Given this list of marker genes Atp1b1 (NCBI Gene Id 11931), Ccdc178, Eef1a1, Clec4b2, Mapk14, Tardbp, Ppp2cb, Chfr, Pdcd6ip, Elmo1, Tlx1, Rtn4rl1, Rit2 (NCBI Gene Id 56511), Sycp3 (NCBI Gene Id 20962), Ugcg, Ppp4r2 (protein phosphatase 4, regulatory subunit 2), Arid4a, Stmn1 (NCBI Gene Id 16765), Larp4b, Gnb1, Stag2, Uso1, Bicd2, Zic2, Dtwd2, Ubxn7, Tmx3, Fam135a, Dnajc21, Hells, Ralgapa2, Xirp2, Tmem265 (transmembrane protein 265), Bahd1, Rab38, Zbtb41, Arl4a, Cd300ld, Ptchd4, Cdan1, Unc5d, Rfxap, Fem1a, Ino80d, Cachd1, Lrrc39, Col11a2, Selenot, Zbed6, Cnn3, Zfp318, Cdkal1, Epop, Ptprr, Specc1l, Ell2, Wipi1, Bhlhe40 (NCBI Gene Id 20893), 1700093K21Rik, Slc25a27 (solute carrier family 25, member 27), Cab39, Itgav, Cpd, Entpd7, Ovol3, Nectin3, Dhrs2, Cdk12, Epm2aip1, Sirt6, Ctnnb1 (catenin beta 1), Zfp84, Clec4a4, Thrb, Cdr1, Ccdc85a, Qrich1, Zfp518a, Amd2, Xkr8, Fem1al, Skil, Amd1, Stim2, Mctp1, Elovl7, Adam22, Rnf169, Ankle1, Cfl2, Ccdc85b, Ccdc141, Adra2a, Itga9, Mocs1, Bend3, Riox2, Tspan18, Srp19, Il12b, Cd109, Elmod1, Zfp324, Kpna3, Grik2, Fxr2, Hmgcr, Itgb1, Ogt (NCBI Gene Id 77137), Kdm7a, Ythdf2, Ncor1, Plpp3, D630003M21Rik, D630045J12Rik, B3glct, here is a description of the gene set: Genes predicted to be targets of miRBase v22 microRNA mmu_miR_7686_5p in miRDB v6.0 with MirTarget v4 prediction scores > 80 (high confidence targets). from publication Chen Y, Wang X (PMID 31504780) studied in species Mus musculus Mouse Gene Set: MIR_7686_5P